The following is a description of a gene set: Genes up-regulated in comparison of memory CD4 T cells versus B cells. In the present study we used Affymetrix oligonucleotide microarrays to produce gene transcription profiles for the major leukocyte types in humans. This comprehensive dataset enabled us to not only establish which genes were expressed in each leukocyte type, but also which genes were expressed in each subset after activation. The used of a comprehensive dataset of gene profiles from all the major human leukocyte subsets enabled a novel and powerful means for identification of genes associated with single leukocyte subsets, or different immune paradigms. studied in species Homo sapiens from publication Jeffrey KL, Brummer T, Rolph MS, Liu SM, Callejas NA, Grumont RJ, Gillieron C, Mackay F, Grey S, Camps M, Rommel C, Gerondakis SD, Mackay CR (PMID 16474395) Human Gene Set: GSE3982_MEMORY_CD4_TCELL_VS_BCELL_UP, and this is the list of marker genes: NEUROG2, NPEPL1, ADRA1D, RORA, MLLT3, ICOS, EFHC2, CETP, WDR76, AK1 (NCBI Gene Id 203), KCNK15-AS1, DDX3Y, NXN, PRKY, PRKCH, CD28, DGKI, SREK1IP1 (NCBI Gene Id 285672), RUSC1, KIF5C, ELAPOR1, TNXB, ENO2 (NCBI Gene Id 2026), CD2, UPP1, IL10RA (interleukin 10 receptor subunit alpha), USP13, CYP1B1, SEMA4C, LIMA1, DPP8, TRMO, PURA, SLC22A18, ENOSF1, EDNRA, PIM1, LPAR6, DPP4, AMMECR1, SH2D1A, SORL1, MYLK3, EPM2AIP1, H3C12, DOK2, ACP6, USP9Y (NCBI Gene Id 8287), CD40LG, ITGA5, NEFL, PHLDA1, SNX29P2, RRM1, CD3D (CD3 delta subunit of T-cell receptor complex), TRAT1, STN1, SLC2A4RG, RGCC, JAKMIP2, MT1F, UBASH3A, KDM5D, HGD, STAT4, ITK, ADGRE5, PLEKHF1, KLRB1, NPRL3, EDN3, CACNB1, SELPLG, PRKCQ, LPIN2 (lipin 2), BTN2A3P, P2RY1, ANO1, CATSPERB, CISH, AKR1C1, PTGER2, LPXN, HOXB2, ESF1, GPR171, TSPAN15, GBP1, CCKBR, HLF, ANKH, ANXA1, TRBC1, SAMHD1, INPP4B, PPFIA4, CERK, CCZ1B, GZMM, ARHGAP33, MED14OS (NCBI Gene Id 730648), ETV3, GUCA2A, PXN, POGLUT1, CSRP3, DNMT1 (NCBI Gene Id 1786), CD6, CD4, IPCEF1, PCDHB13, ZNF12, DLEC1, CNGB1, TAOK3, BCL9, TRAC, CAND2, ITGA6, MAN2A1, DUSP4, DENND1B, CLUH, CALM1, GRAP2, SCTR (secretin receptor), PHACTR2, TMPRSS3, MC4R, IL2RB (NCBI Gene Id 3602), RASGRF1, DGCR8, PAM, ATXN1, PTPRM, NINJ1, CD96, ZFPM2, PLXDC1, SEPTIN9, NDNF, DCHS1, GATA3 (GATA binding protein 3), RBMXL2, ULK2, TNNC1, ATRNL1, GIMAP4, CXCL6, PPA1, TNPO3, GLRA2, IL32, MVB12B, FBXO22 (NCBI Gene Id 80234), PHOX2A, PSTPIP2, CHN1, CFH (complement factor H), KRTAP1-3, ZAP70, SEMA4D, SMIM7, BCL11B, MRC2, RPS4Y1, IFITM1 (NCBI Gene Id 8519), PLSCR3, CASP6, BRINP3, FRMD4B, MICAL2, DLG3, GUSBP14 (GUSB pseudogene 14), GIMAP5, FOXO3, PAH, FRY, LCP2, LATS1, GIMAP6, TNC, CD3E, PLS1, SASH1, RRAGD, LCT, SEC31B, CGREF1, DLX4, CCN3, HOXD10, LRRFIP1, TMEM144, GZMK, CD3G, HUWE1, LCK, CAPN9